The following is a description of a gene set: studied in species Mus musculus A renal system process in which fluid circulating through the body is filtered through a barrier system. Mouse Gene Set: GOBP_RENAL_FILTRATION, and this is the list of marker genes: Ednra, Uts2r, Comt, Coro2b, F2rl1, Mcam, Cd34, Gas6, Rhpn2, Gja1, Sulf2 (sulfatase 2), Pdgfb, Cyba, Xpnpep3, Umod, Tmem63c, Emp2, Itga3, Ppp3ca, Edn1, Ptpro, Ttr, Aqp1, Adgrf4, Adora1, Sulf1, Kirrel1, Myo1e, Adgrf5, Uts2, F2r, Jchain, Rhpn1, Tbc1d8b, Gja5